Given this list of marker genes Stap1, Cx3cr1, P2rx4, Csf1, P2ry12, Cx3cl1, Trem2, Enpp1, here is a description of the gene set: studied in species Mus musculus The orderly movement of a microglial cell from one site to another. Mouse Gene Set: GOBP_MICROGLIAL_CELL_MIGRATION